Given this list of marker genes Slc6a15, Slc6a5, Slc18a2, Slc6a2, Slc6a19, Slc6a11, Slc6a7, Slc6a3, Slc6a13, Slc18a1, Slc6a18, Slc6a12, Slc22a2, Slc22a1, Slc6a14, Slc6a9, Slc6a1, Slc6a20a, Slc6a6, here is a description of the gene set: species: Mus musculus Na+/Cl- dependent neurotransmitter transporters Mouse Gene Set: REACTOME_NA_CL_DEPENDENT_NEUROTRANSMITTER_TRANSPORTERS